Given this list of marker genes Enah, Cyp4b1, Inmt, Postn, Meox2, Rab28, Sash1, Actc1, Rptn, Kit, Igfbp6, Sox11, Myl9, Ahr, Cdh11, Zbtb46, Ccn5, Cav1, AW112010, Qki, Ckmt2, Itpkb, Dpep1, Ankrd10, Peg3, Reg3g, Fermt2 (NCBI Gene Id 218952), Dpt, Mtss2, Fxyd1, Stmn3, Ltb, Usp18, Adcy8, Dcn, Sema7a, Scn7a, Vcl, C3, H2ax, Gbp3, Serping1, Gbp7, Rab12, Cfd, Cavin3, Vegfa, Pag1, Kalrn, Sparcl1, Krt13, Tfrc, Srgn, Grem2, Crhr1, Myl4, Rbp1, Ndn, Adarb1, Ccrl2, Sult1d1 (sulfotransferase family 1D, member 1), Tcf3, Siah1a, Myl7, Map7d1, Clic4, Pmp22, Bpifb1, Cyp2b10, Rarres2, Wwtr1, Tnnc1, Ggh, Vax1 (NCBI Gene Id 22326), Fgf9, Icam2, Npr3, Pkd2, Tnni3, Mgp, Rdh11, Arhgef3, Tspan7, Tnfrsf19, Sh3bp5, Col1a2, Nt5dc2, Acta2, Hp, Gpr182, Epas1, Sparc, Cxcr4, Spef1, Sspn, Ablim1, Eps15, Efnb2, Tgtp1, Ptch1, Lama2, Rasip1, Fez2, Lats2, Gfra2, Gpc3, Gnasas1, Npnt, Bpgm, Tbx3, Pgrmc1, Hoxa6, Cavin2, Plac9, Msln, Ifit3, Cdr2, Cyp2e1, Acta1, Zbtb20, Klf7, Lifr, Col6a2, Cavin1 (NCBI Gene Id 69669), Cidec, Il6st, Hnrnpa1, Atoh7, Aldh1a7 (NCBI Gene Id 26358), Myh6, Mpdz, Thbd, Aldob (NCBI Gene Id 230163), Papss2, Adrb3, Ms4a1 (membrane-spanning 4-domains, subfamily A, member 1), Shox2, Krt85, Hey1, Edn1, Bnc1, Cldn5, Atp2a2, Kctd12, Myzap, Dusp1, Tiam1, Notch4, S100a8, Ces1d, Pdgfra, Ptgis, Ppp2r3c, Kitl, Ly6a, Top2a, Usf2, Pdlim1, G0s2, Zeb1, Atp1a2, Ankrd1, Ctla2a, Hck, Cd93, Myb, Eng, Ifitm3, Ptprb, Hba-ps3, Col3a1, Acvrl1, Il1b, Calcrl, Emp2, Col13a1, Lamb1, Pon1, Cd47, Ighd, Ces2g, Serpina3c, Satb1, Tent5c, Mfap5, Aqp1, Pck1, Rcn1, St8sia4, Ms4a6b, Adrb2, Foxf1, Abca1, Ltbp4 (latent transforming growth factor beta binding protein 4), Vwf, Antxr2, Lyl1, Stmn2, Angpt1, Epb41, Tspan6, Ptges, Slco3a1, Hbb-bs, Ackr2, Gsta3, Lysmd2, Fas, Ace, Gpm6b, Tspan13, Ppp1cb, Stab1, Adh1, Ifi203, Id3, Ednrb (endothelin receptor type B), Ctla2b, Cckar, Ankrd33b, Klra3 (killer cell lectin-like receptor, subfamily A, member 3), Tprg1l, Sesn1, Ms4a4d, Tmem45a, Bmyc, Hsd11b1, Tagln, Cyp2a4, Macf1, Tcf4, Fhl1, Armcx2, Fgf7, Cfhr4, Alas2 (aminolevulinic acid synthase 2, erythroid), Art3, Klf9, Grk5, Cdh5 (NCBI Gene Id 12562), Bub1 (BUB1, mitotic checkpoint serine/threonine kinase), Timp3, Cacnb2, Pdgfrb, Gpx3, H2bc4, Adgre5, Pgm2, Rhob, Dipk2a, Spa17, Plpp3, Foxf2, Il11ra1, Tango2, Sc5d, Cdk14, Klf2, Trbc1, Zbtb16, Nfkbia, Sox17, Slc4a5, Numb, Mapt, Gnb4, Sptan1, Emcn, Robo1, Plpp1, Smarca2, Cyp2b9, Marcks, Cox7a1, Prom1, Glul, Rgs2, Zmynd11, Psmb10, Scgb1a1, Gpam (glycerol-3-phosphate acyltransferase, mitochondrial), Spib, Tfpi, Sod3, Mfap2, Calcr, Mfhas1, Cdkn1c, Ahnak, Ackr3, Hoxb5, Igfbp5, Il27ra, Flt1, Loricrin, Ccn1, Car3, Loxl1, Enpp2, Cyth3, Ets1, Gadd45b, Dennd2b, Pltp, Ntn1, Sox2, Ogn, Nid1, She, Pcdha4, Col1a1, Rhoj, Tph1, Bcl6b, Snca, Ifi205, S100a9, Dnm1 (NCBI Gene Id 99078), Clec3b, Prdx6, Sult1a1, Tuba1a, Mef2c, Gbp2, Rabggta, Dennd4c, Tns2, Hoxa5, Tnnt2, Car2, Hopx (NCBI Gene Id 74318), Jun (NCBI Gene Id 16476), Sptbn1, Fgl2, Myl3, Tm2d3, Scel, Myh1, Igfbp2, Xist, Gimap4, Kdr, Arxes2, Cdo1, Tnxb, Gyg1, Heph (hephaestin), Ramp2, Lmo2, Abcc1, Psip1, Lepr, Nr2f2, Upk3b, Septin4, Tekt1, Prkce, Sorbs1, Tmem71, Sema3c, Cadm1, Ptprd, Spock2, Kank3, Gsn, Nfib, Gmfg, Meis1, Cpe, Myo1b, Twsg1, Smad6, Bdnf, Vegfd, Ankrd40, Bmp6, Cntn1, Epha5, Tek, Ndrg2, Fyn, Prx, Cfhr1, Omd, Gng11, Inpp5a, Angptl2, Lyve1, Tnnt3, Myh11, Tie1, Pam, Arrb1 (NCBI Gene Id 74110), Cp, Klf4, Slc10a2, Tmeff1, Cxcl14, Ackr4, Gucy1b1, Cfh, Fmo3, Fmo1, Cyp2s1, Ndst1, Tcf21, Ets2, Vamp3, Ccl21a, Reck, Acsl1, Myo6, Ripor2, Adipoq, Pkia, Tjp1, Limch1, Aldh1a1, Lin9, Cyp2f2, Map4, Surf2, Slc7a5, Akap12, Gstm2, Acvr2a, Fkbp9, Ifih1, Lox, Metap1 (methionyl aminopeptidase 1), Krt4, Tbx2, Cav3, Gng2, Crip1, here is a description of the gene set: studied in species Mus musculus Mouse Gene Set: SWEET_LUNG_CANCER_KRAS_DN Using advanced gene targeting methods, generating mouse models of cancer that accurately reproduce the genetic alterations present in human tumors is now relatively straightforward. The challenge is to determine to what extent such models faithfully mimic human disease with respect to the underlying molecular mechanisms that accompany tumor progression. Here we describe a method for comparing mouse models of cancer with human tumors using gene-expression profiling. We applied this method to the analysis of a model of Kras2-mediated lung cancer and found a good relationship to human lung adenocarcinoma, thereby validating the model. Furthermore, we found that whereas a gene-expression signature of KRAS2 activation was not identifiable when analyzing human tumors with known KRAS2 mutation status alone, integrating mouse and human data uncovered a gene-expression signature of KRAS2 mutation in human lung cancer. We confirmed the importance of this signature by gene-expression analysis of short hairpin RNA-mediated inhibition of oncogenic Kras2. These experiments identified both a pattern of gene expression indicative of KRAS2 mutation and potential effectors of oncogenic KRAS2 activity in human cancer. This approach provides a strategy for using genomic analysis of animal models to probe human disease. from publication Sweet-Cordero A, Mukherjee S, Subramanian A, You H, Roix JJ, Ladd-Acosta C, Mesirov J, Golub TR, Jacks T (PMID 15608639) Genes down-regulated in the Kras2LA mouse lung cancer model with mutated KRAS.